Given this list of marker genes Cavin4, Barx2, Lmod1, Glmn, Tcf23, Mymk, P2rx2, Tnfsf14, Tmod1, Csf1r, Foxp1, Norad, Ank2 (NCBI Gene Id 99906), Tgfb1, Mir351, Zmpste24, Flnc, Mtpn, Mef2a, Atp2a2, Dmpk, G6pd2, Tarbp2, Ldb3, Bin1, Ehd2, Hacd1, Tshz3 (NCBI Gene Id 338507), Znhit1, Kdm6b, Kit, Adamts5, Sox6, Csrp1, Met, Myorg, Fbxo22, Cth, Wfikkn1 (WAP, FS, Ig, KU, and NTR-containing protein 1), Gata4, Ereg, Or10j5, Lamb2, Igfbp5, Wt1, Tmsb4x, Myh10, Bcl9, Mesp1, Sdc1, Speg, Il4ra, Tomm70a, Rbpms2, Il36g, 3425401B19Rik, Asf1a, Ttn, Pdlim5, Mtln, Nek5, Sod2, Ccn3, Klf5, Xk (X-linked Kx blood group), Smarca4, Ccnt2, Lmod3, Yy1, Cxcl10, Zbed6, Neo1, Vangl2, Prox1, Bmp10, Sema4c, Trim72, Notch2, Cacna1s, Itgb1, Ctcf, Cxcl9, Ctdp1, Parp2, Ankrd2, Stim1, Cdon, Efemp2, Cntnap2, Pld3, Notch4, Trim63, Tbx1, Sirt6, Gdf15, Ptgfrn, B4galnt2, Popdc3, Cripto (NCBI Gene Id 235635), Csrp3, Adprhl1, Syna, Mylk3, Fgf10, Sirt1, AW551984, Rbm4, Il4, Setd3, Hdac5, Cfh, Gata6, Slc9a1, Olfm2, Klhl41, Ppara, Acvr1, Id2, Fktn, Sox9, Prdm6, Tbx3, Tnnt2, Hes1, C3, Tmod4, Tpm1, Six1, Greb1l, Wdr1, Tmod2, Myom2, Atg5, T, Flii, Neb (NCBI Gene Id 99028), Ifrd1, Ppp3ca, Lncpint, Uchl1, Mecp2, Prkg1 (protein kinase, cGMP-dependent, type I), Hopx, Tnnt1, Hira, Piezo1, G6pdx, Wnt3a, Klhl40, Rbpj, Prok2 (NCBI Gene Id 50501), Kel, Lama1, Rarb, Ins2, Hey1, Mfn2 (mitofusin 2), Cd9, Ptcd2, Itga8, Ntf3, Mir143, H3f3a, Rxra, Hdac3, Rcan1, Ednra, Arid1a, Tmtc3, Cacybp, Actn2, Synpo2l, Isl1, Trip10, Hdac4, Grem1, Dock5, Camk1, Igfn1, Smo, Dock1, Epc1, Ccnd2, Casq1, Sorbs2, Qki, Mir208b, Cdk1, Myom3, Myc, Nln (NCBI Gene Id 97876), Casp3, Trim32, Fhl2, Mymx, Prkd1, Myf6, Smarcd3, Spag9, Mir208a, Prkar1a, Ezh2, Prickle1, Edn1, Nphs1, Med28, Capn2, Pin1, Cyp26b1, Meis1, Neu2, Tcap, Dkk1, Cd53, Selenon, Smarca2, Mybpc1, Pdgfra, Actn3, Fdps, Akap6, Fbxo40, Kdm1a, Bhlhe41, Pi16, Fhod3, Xirp1, Foxo4, Vegfa, Hottip (Hoxa distal transcript antisense RNA), Ednrb, Cav2, Syne1, Acta1, Svil, Lamc1, Nrap, Krt8, Foxf1, Adm (NCBI Gene Id 11535), Ski, Wfikkn2, Alpk2, Dusp29, Nfatc2, Plec, Pdgfrb, Large1 (NCBI Gene Id 17871), Rara, Myl2, Ift88, Casq2, Pak1, Capn3, Pin1rt1, Rbm24, Maml1, Cfd, Msx1, Morf4l2, Tmem204, Neurl2, Fgf9, Dner, Casp1, Myh11, Synb, Adgrb1, Lmod2, Wnt5b (NCBI Gene Id 22419), Asb2, Akirin2, Cacnb4, Ripor2, Hnrnpu, Atg7, Bnip2, Igf1, Ybx1, Nrg1, Mylk2, Cav3, Ankrd17, Cdh2, Rbm10, Fgfr2, Myhas, Mdm2, Bhlha15, Chuk (NCBI Gene Id 12675), Gper1, Flot1, Arrb2, Myoz1, Rora, Wnt7b, Fer1l5, Nfatc4, Nfatc3, Acadm, Ankrd23, Mir499, Sik1, Adra1a, Nebl, Sgcd, Lox, Tmod3, Adgrb3, Nkx2-5, Bves, Nid1, Six4, Hdgfl2, Bcl2, Kcnj8, Akt1, Sypl2, Ddx39b, Flt3l, Cntnap1, Cfl2 (cofilin 2, muscle), Myl9, Hdac2, Mtor, Calr, Smyd3, Dll1, Csrp2, Mir145a, Adamts15, Gpx1, Myof, Wnt4, Tbx18, Tsc1, Hand2, Actn1, Npnt, Cd81, Adra1b, Bdnf, Myog, Dyrk1b, Agt, Gsk3a, Krt19, Srf, Kat2a, Pdcd4, Kras, Comp, Slc8a1, Atp11a, Lbx2, Col14a1, Cxadr, Rbm38, Mmp14, Bmp4, Zfp418, Ntn3, Mapk14, Dpf3, Smyd1, Bmpr1a, Cby1, Hey2, Mrtfa, Sgcb, Chrnb1, Ppp3cb, Ang2, Dnmt1, Nkx2-6, Mybpc3, Cdk9, Ep300, Mybph, Ehd1, Casp7, Tbx5, Stac3, Plekho1, Eng, Nox4, Bvht, Daxx, Megf10, Myom1, Cacna2d2, Col6a1, Bmpr2, Wnt1, Pgm5, Smad1, Fkrp, Pax3, Nfatc1, Tnnt3, Homer1, Akap13, Rgs2, Ramp2, Ryr1, Tbx2, Irx3, Mybpc2, Ccl8, Naglu, Popdc2, Myocd, Plpp7, Hdac9, Bin3, Ptbp1, Dmd, Gsk3b, Actn4, Igf2, Scgb3a1, Dyrk1a, Rgs4, Bmp2, Smad4, Ift20, Xbp1, Dicer1, Dock2, Frs2, Dcaf8, Wnt10b, Actc1, Dysf, Spg11, Ctnnb1, Hamp2, Agtr2, Efnb2, Camk2d, Myh9, Aplnr, Supt6, Alpk3, Pdgfb, Myoz2, Avpr1a (NCBI Gene Id 54140), Tanc1, Myf5, Myh6, Rpl3l, Lama2, Pmp22, Nr3c1, Afg3l2, Adrb1, Ppif, Zeb1, Sort1, Mypn, Lrrc10, Fzd7, Tnpo2 (transportin 2 (importin 3, karyopherin beta 2b)), Mef2c, Lmna, Shh, H3f3b, Smad6, Lamb1, Mamstr, Rb1, Mrtfb, Myod1, Hamp, Pitx2, Pbrm1, Pias1, Shox2, Notch1, Actg1 (actin, gamma, cytoplasmic 1), Rxrb, Slc25a4, Eif5a, Ccn4, Myo18b, Cxcl12, Tmem119, Tmem182, Cflar, Ninj1, Map2k4, here is a description of the gene set: studied in species Mus musculus Mouse Gene Set: GOBP_MUSCLE_CELL_DIFFERENTIATION The process in which a relatively unspecialized cell acquires specialized features of a muscle cell.